The following is a description of a gene set: Ventilator dependence with inability to wean Human Gene Set: HP_VENTILATOR_DEPENDENCE_WITH_INABILITY_TO_WEAN species: Homo sapiens, and this is the list of marker genes: TRMU, ALAD, IGHMBP2, MT-TE, TK2